Given this list of marker genes Nat8f2, Bex4, Pcp4, Ubd, Art3, Mup4, Prdx2, Mup3, Hebp1, Ctsc, Thrsp, Mug-ps1, Rbp4, Bag2, Mup5, Ddx6, Psmb5-ps, here is a description of the gene set: BACKGROUND AND AIMS: The gastrointestinal trefoil factor family (TFF1, TFF2, TFF3) peptides are considered to play an important role in maintaining the integrity of the mucosa. The physiological role of TFF2 in the protection of the GI tract was investigated in TFF2 deficiency. METHODS: TFF2-/- mice were generated and differential expression of various genes was assessed by using a mouse expression microarray, quantitative real time PCR, Northern blots or immunohistochemistry. RESULTS: On an mRNA level we found 128 differentially expressed genes. We observed modulation of a number of crucial genes involved in innate and adaptive immunity in the TFF2-/- mice. Expression of proteasomal subunits genes (LMP2, LMP7 and PSMB5) involved in the MHC class I presentation pathway were modulated indicating the formation of immunoproteasomes improving antigen presentation. Expression of one subunit of a transporter (TAP1) responsible for importing degraded antigens into ER was increased, similarly to the BAG2 gene that modulates chaperone activity in ER helping proper loading on MHC class I molecules. Several mouse defensin (cryptdin) genes coding important intestinal microbicidal proteins were up-regulated as a consequence of TFF2 deficiency. Normally moderate expression of TFF3 was highly increased in stomach. Mouse Gene Set: BAUS_TFF2_TARGETS_DN from publication Baus-Loncar M, Schmid J, Lalani el-N, Rosewell I, Goodlad RA, Stamp GW, Blin N, Kayademir T (PMID 16121031) Genes down-regulated in pyloric atrium with knockout of TFF2. species: Mus musculus